The following is a description of a gene set: Mouse Gene Set: GOBP_REGULATION_OF_MITOCHONDRIAL_TRANSCRIPTION studied in species Mus musculus Any process that modulates the frequency, rate or extent of transcription occurring in the mitochondrion., and this is the list of marker genes: Sirt3, Kat8, Kansl1, Tefm, Prkaa1, Mtres1, Thap11, Mettl4, Kansl3